Given this list of marker genes KIF11 (kinesin family member 11), ABHD4, PAK1, COMMD8, TALDO1, TMEM165, TSC22D4, ASNSD1, MGAT5, PFKFB3, RAPH1, SLC16A7, FERMT3 (FERM domain containing kindlin 3), BPHL, YTHDC2, CYP4V2 (NCBI Gene Id 64587), TSPAN14, RSRP1, MCM4, PRIM1, AKAP11, ZFYVE1, R3HDM1, SARAF, CACUL1, RETREG2, SSH2, RTN3, PDXDC1, RMND1, TEX261, TIA1, DPP4, GATM, RANBP6, SPTBN1, TP53INP2, GPR180, EDEM3, LHFPL2, SLBP, TMCC3, TRMT2B, DDX3X, CDK2, SQOR, NEURL2, NACC2, IER5L, ABTB1, RPS6KA1, RCHY1, VPS41, RNF130, BTBD3, DYNLT1, NAT9, ZNF600, KIF13B, STK38, ENTPD4, MTSS1, VPS4B, NAGK, ZNF467, DOLK, EPB41L3, HERC1, PRRG1, UBL3, LBH, GAS2L3, SNRK, UHRF2, MROH1, TSC22D1, MFSD12, HAUS1, MBTPS1, GSN, OPHN1, INSR, ASXL2, EHMT1, LUC7L3, POGLUT2, NDUFS7, BAMBI, PPWD1, GAN, YEATS4 (NCBI Gene Id 8089), GMIP, MCRIP2, LRRC27, AP4M1, CCNDBP1, HMG20A, CTDSPL, OSBPL2, OMA1, ARMC10, CDKAL1, MON1A, CCDC28A, ASAH2, IDS, LRP1, HFE, RAB11FIP5, GET1 (guided entry of tail-anchored proteins factor 1), REPS2, NDST2, TMEM245, TPST2, UGP2, SIDT2, ABHD17A, NAGA (alpha-N-acetylgalactosaminidase), TBC1D2, PHF21A, NCBP2AS2, GOT1, DEAF1, CEP83-DT, MPHOSPH9, AGO3, HPCAL1, TBC1D9, ZNF746, PTPN18, IGIP, NT5M, NCF2, P2RX7, DAGLB, PREPL, HS1BP3, WDSUB1, SULF2, FAM193A (NCBI Gene Id 8603), RELL1, TAX1BP1 (Tax1 binding protein 1), PRC1, SLC38A10, AMOT, TRAFD1 (TRAF-type zinc finger domain containing 1), TLR3, CAMK1 (calcium/calmodulin dependent protein kinase I), PGGT1B, NSMCE4A, DHX34, DMAC2L, MCM6, DTNBP1, AURKA, MGST1, SMPDL3A, PURG, RELCH, INPP5D, SLC35F5, ZNF708 (NCBI Gene Id 7562), SLC25A11, NSD1, AMDHD2, DCAF8, ZCCHC8, CHAF1B, GADD45G, NUDT16L1, BLNK, FADS1, IDH2, BEND4, ZBTB45, WDR13, C1orf54, PPIL2, RAF1 (Raf-1 proto-oncogene, serine/threonine kinase), GSK3B, PHOSPHO2, APC, TCIRG1, TTF2, LY96, MAVS, CLASP2, SDHAF4, DUSP3, LANCL2, KANK3 (KN motif and ankyrin repeat domains 3), ZBTB11-AS1, EYA4, PLEKHM3, DCTN5, TM6SF1, CTBP1, TTYH2, RBL1, here is a description of the gene set: from publication Min L, Isa SA, Fam WN, Sze SK, Beretta O, Mortellaro A, Ruedl C (PMID 22250091) Human Gene Set: GSE32986_GMCSF_AND_CURDLAN_LOWDOSE_VS_GMCSF_AND_CURDLAN_HIGHDOSE_STIM_DC_UP species: Homo sapiens Genes up-regulated in bone marrow-derived dendritic cells treated by CSF2 and 1,3-beta-D-oligoglucan: low dose versus high dose. A simultaneous engagement of different pathogen recognition receptors provides a tailor made adaptive immunity for an efficient defence against distinct pathogens. For example, cross talk of TLR and c-type lectin signalling effectively shapes distinct gene expression patterns by integrating the signals at the level of NF-κB. Here, we extend this principle to a strong synergism between the Dectin-1 agonist, curdlan, and an inflammatory growth factor, GM-CSF. Both together act in synergy in inducing a strong inflammatory signature which converts immature DCs to potent effector DCs. A variety of cytokines (IL-1β, IL-6, TNF-α, IL-2 and IL-12p70), costimulatory molecules (CD80, CD86, CD40 and CD70), chemokines (CxCl1, CxCl2, CxCl3, CCl12, CCl17) as well as receptors and molecules involved in fugal recognition and immunity such as Mincle, Dectin-1, Dectin-2 and Pentraxin 3 are strongly up-regulated in DC treated simultaneously with curdlan and GM-CSF. The synergistic effect of both stimuli resulted in strong IKBα phosphorylation, in its rapid degradation and in enhanced nuclear translocation of all NF-κB subunits. We further identified MAPK ERK, as one possible integration site of both signals, since its phosphorylation was clearly augmented when curdlan was co-applied with GM-CSF. Our data demonstrate that the immunomodulatory activity of curdlan requires an additional signal provided by GM-CSF to successfully initiate a robust β-glucan specific cytokine and chemokine response. The integration of both signals clearly prime and tailor a more effective innate and adaptive response against invading microbes and fungi.